Given this list of marker genes F13b, Hsd3b2, Hsd17b1, Hsd17b4 (hydroxysteroid (17-beta) dehydrogenase 4), Hsd3b5, Hsd3b3, Cyp17a1, Hsd3b4, Hsd17b2, Hsd3b1, Hsd17b7, Hsd17b3, Hsd3b6, here is a description of the gene set: Mouse Gene Set: WP_STEROID_BIOSYNTHESIS Steroid biosynthesis studied in species Mus musculus